Given this list of marker genes HDAC3, DKK1, BMP2, MIR222, SMAD4, DLL1, FRS2, SOX6, HEY2, EGFR, MIR200B, MIR590, PRICKLE1, FZD7, here is a description of the gene set: studied in species Homo sapiens Human Gene Set: GOBP_NEGATIVE_REGULATION_OF_CARDIOCYTE_DIFFERENTIATION Any process that stops, prevents or reduces the frequency, rate or extent of cardiocyte differentiation.